The following is a description of a gene set: Human Gene Set: MIR5681B from publication Chen Y, Wang X (PMID 31504780) species: Homo sapiens Genes predicted to be targets of miRBase v22 microRNA hsa-miR-5681b in miRDB v6.0 with MirTarget v4 prediction scores > 80 (high confidence targets)., and this is the list of marker genes: SAXO1, MTF2, CCDC177, GAPVD1, PIK3R1, FBXO8, DNAJC14, COX10, NHS, CLMP, FAM156A, PRDM6, FREM1, MMUT (NCBI Gene Id 4594), TCEAL9, PPARGC1B, IGF2BP3, BECN1, COX11, PNKD, SCYL3, DNAJB1, KRT6B, DTWD2, AGPS, SH3GLB1, CREB5, ANTXR1, IKZF2, HDAC9, ADD3 (NCBI Gene Id 121), TENT5D, PLEKHA3, RAP1B, NSRP1, FAM156B, ZNF334, PHIP, JMY (NCBI Gene Id 23651), MAP4K4 (mitogen-activated protein kinase kinase kinase kinase 4), AK9, VEZF1, MYCN, VWA5A, KMT5B, NUP160, ZBTB44, WAC, SEC24C, RND2, DNAJB5, ALOX5AP, RCOR1, IKZF4, GABRP